The following is a description of a gene set: Human Gene Set: GOBP_POSITIVE_REGULATION_OF_FATTY_ACID_OXIDATION Any process that activates or increases the frequency, rate or extent of fatty acid oxidation. studied in species Homo sapiens, and this is the list of marker genes: CPT1A, ABCD1, MLYCD, PPARGC1A, AKT2, ABCD2, GDF15, PLIN5, TWIST1, PPARD, IRS1 (insulin receptor substrate 1), MTLN, KLHL25, PPARA, IRS2